Given this list of marker genes Il5ra, Dennd6a, Gpn1, St3gal4, Tacc1, Hrk, Stk4, Skint3, Krt82, Mgarp, Cpeb3, St8sia2, Bod1 (NCBI Gene Id 69556), Mospd1, Aldh1l2, Ssbp2, Sp8, Ddo, Sec14l3, Ctla2b, Msln, Siglecf, Capza2, Plcl1, Armc8, Car5b, Iqcj, Gorasp2, Col22a1, Pcdh15, Stmn2, Dctn5, Dst, Mdga2, Tmem150b, Eml1, Kctd3, Ids, Cox7c, Dock3, Ntrk2, Hoxa9, Bmt2, Meis2, Pigv, Rnf150 (ring finger protein 150), Zfp229, Gpbp1, Ablim1, Elf1, AU018091, Ccdc96, Napb, Prkd2, Hapln1, Unc13c, Uqcc4, Edn2, Zswim1, Cldn17, Tmem273, Tiparp, Zfp383, Slc31a2, Esco1, Yeats4, Ccdc59, Ets1, Egln3, Ska1, Nrxn3, Gm8817, Serp1 (NCBI Gene Id 28146), Wasf2 (NCBI Gene Id 52063), Phc3 (NCBI Gene Id 319628), Wdr26, Fbxo11, Tma16, Vmn2r43, Sesn1, Ccdc121rt2, Tmprss11e, Zc3h6, Lats2, Soat1, Ube2f, Zfp113, Sema5a, Insr, Pbld2, Ttc9c, Ttll7, Ccdc102a, Acss3, Gatad1, Fam32a, Rimklb, Gnai1, Rfx3, here is a description of the gene set: from publication Chen Y, Wang X (PMID 31504780) Genes predicted to be targets of miRBase v22 microRNA mmu_miR_3089_5p in miRDB v6.0 with MirTarget v4 prediction scores > 80 (high confidence targets). Mouse Gene Set: MIR_3089_5P studied in species Mus musculus